The following is a description of a gene set: part of: Organelle biogenesis and maintenance Mitochondrial biogenesis and remodeling occur in response to exercise and redox state. It is hypothesized that calcium influx and energy depletion are the signals that initiate changes in gene expression leading to new mitochondrial proteins. Energy depletion causes a reduction in ATP and an increase in AMP which activates AMPK. AMPK in turn phosphorylates the coactivator PGC-1alpha (PPARGC1A), one of the master regulators of mitochondrial biosynthesis. Likewise, p38 MAPK is activated by muscle contraction (possibly via calcium and CaMKII) and phosphorylates PGC-1alpha. CaMKIV responds to intracellular calcium by phosphorylating CREB, which activates expression of PGC-1alpha.<br>Deacetylation of PGC-1alpha by SIRT1 may also play a role in activation, however Sirt11 deacetylation of Ppargc1a in mouse impacted genes related to glucose metabolism rather than mitochondrial biogenesis and mice lacking SIRT1 in muscle had normal levels of mitochondrial biogenesis in response to exercise so the role of deacetylation is not fully defined. PGC-1beta and PPRC appear to act similarly to PGC-1alpha but they have not been as well studied.<br>Phosphorylated PGC-1alpha does not bind DNA directly but instead interacts with other transcription factors, notably NRF1 and NRF2 (via HCF1). NRF1 and NRF2 together with PGC-1alpha activate the transcription of nuclear-encoded, mitochondrially targeted proteins such as TFB2M, TFB1M, and TFAM. Reactome Pathway: Mitochondrial biogenesis studied in species Homo sapiens, and this is the list of marker genes: NCOA1, TWNK, CHCHD6, TFB1M, ATP5PF, MAPK12, MEF2C, SMARCD3, PPARGC1A, ATP5PO, GABPB1, ATP5F1A, CREB1, NCOR1, DMAC2L, CYCS, ATP5PB, PRKAG2, ATP5F1B, GLUD1, NRF1, ATP5F1E (ATP synthase F1 subunit epsilon), MICOS10, MT-ATP6, TFB2M, PPARA, ATP5F1D, CHCHD3, MT-ATP8, NCOA2, HCFC1, POLG2, SAMM50, PPARGC1B (PPARG coactivator 1 beta), TMEM11, CALM1, PPRC1 (PPARG related coactivator 1), TBL1X, MAPK14, MAPK11, PRKAB1, APOOL, TBL1XR1, SIRT3, APOO, TGS1, SOD2, PRKAG3, SIRT5, SIRT4, MTX2, ATP5MC3, CREBBP, NR1D1, HSPA9, ACSS2, CRTC3, PERM1, ATP5MK, ALAS1 (5'-aminolevulinate synthase 1), ATP5MC1, CARM1, NCOA6, IMMT, MTX1, ATF2, PRKAA2, HDAC3, ATP5MG, DNAJC11, HELZ2, PRKAB2, ATP5PD, SSBP1, MED1, CHD9, RXRA, POLRMT, ATP5F1C, MEF2D, ATP5MC2, PRKAG1, CAMK4, ATP5MJ, CRTC2, ATP5ME, ATP5MF, GABPA, ESRRA (NCBI Gene Id 2101), TFAM, IDH2 (NCBI Gene Id 3418), MTERF1, CRTC1, GLUD2, MICOS13